Given this list of marker genes AGO3, AGO2, MOV10, AGO1, TNRC6B, AGO4, TNRC6C, PTEN, TNRC6A, here is a description of the gene set: species: Homo sapiens Regulation of PTEN mRNA translation Human Gene Set: REACTOME_REGULATION_OF_PTEN_MRNA_TRANSLATION